The following is a description of a gene set: Human Gene Set: GOCC_MHC_PROTEIN_COMPLEX studied in species Homo sapiens A transmembrane protein complex composed of an MHC alpha chain and, in most cases, either an MHC class II beta chain or an invariant beta2-microglobin chain, and with or without a bound peptide, lipid, or polysaccharide antigen., and this is the list of marker genes: HLA-DPA1, B2M, CD74, HLA-C, HLA-F, HLA-DOB, HLA-DQA2, HLA-A, HLA-DRB5, HLA-DPB1, HLA-E, MR1, HLA-DQB2 (NCBI Gene Id 3120), HLA-DRB3, HLA-DOA, HLA-DRB1, HLA-DRB4, HLA-DMB, HLA-DQB1, HLA-B, HLA-DMA, HLA-DQA1, HLA-H, HLA-G, HLA-DRA, HFE